Given this list of marker genes NAA10, LHX3 (NCBI Gene Id 8022), RNU12, PEX26, TSHR, SLC5A5 (NCBI Gene Id 6528), TSHB, GPX4, IYD, INTU, LHX4, TG, TPO, PROP1, POU1F1, DUOX2, HESX1, DUOXA2, PAX8, here is a description of the gene set: Large posterior fontanelle Human Gene Set: HP_LARGE_POSTERIOR_FONTANELLE An enlargement of the posterior fontanelle relative to age-dependent norms. species: Homo sapiens